Given this list of marker genes WWOX, TFAP2A, SUMO1, TFAP2C, KCTD15, KCTD1, TFAP2E, TFAP2D, UBE2I, TFAP2B, here is a description of the gene set: species: Homo sapiens Human Gene Set: REACTOME_NEGATIVE_REGULATION_OF_ACTIVITY_OF_TFAP2_AP_2_FAMILY_TRANSCRIPTION_FACTORS Negative regulation of activity of TFAP2 (AP-2) family transcription factors